The following is a description of a gene set: Temporal analysis of B cell activation in vitro using CD40L and IL-2/4/5 cytokines in wild type Irf4+/+ B cells or in mutant Irf4-/- B cells harboring a tet-inducible allele of Irf4. IRF4 expression was restored, or not, in the Irf4-/- background by culturing in the presence of low or high concentrations of doxycycline. The results provide insight in the role of IRF4 expression levels in coordinating different programs of B cell differentiation. Genes up-regulated in CD40L and IL-2 IL-4 IL-5 stimulated at day 1 B cell IRF4intermediate versus CD40L and IL-2 IL-4 IL-5 stimulated at day 1 B cell wildtype. from publication Ochiai K, Maienschein-Cline M, Simonetti G, Chen J, Rosenthal R, Brink R, Chong AS, Klein U, Dinner AR, Singh H, Sciammas R (PMID 23684984) Human Gene Set: GSE46606_IRF4MID_VS_WT_CD40L_IL2_IL5_DAY1_STIMULATED_BCELL_UP studied in species Homo sapiens, and this is the list of marker genes: NKAPL, TENT5C, ZNF250, PLXNC1, GINS1, HAGH, METTL9, CENPK, SGK1, POLR1D, VMAC, FAM78A, EPS8, TTC14, KMT2C, DTYMK, IFT70B, TSPYL4, ABCG1, APPL2, GTF2I, MKNK2, SEC22C, LAGE3, VAMP1, TXNIP, RAB11FIP5, IRAG2, GIGYF1, THBD, ZC3H12D, DIRAS2, KLF17, C2, KBTBD3, PWWP2B, SELENOH, RP9, MRM2, PDXK, PTPA, LSR, TCTN3, CDK20, COMT, ZNF124, SLC37A2, IFT140, STRBP, NHLRC2, TMEM18, ERCC6, E2F8, SKI, DENND4C, PCYOX1, NATD1, DDX31, SLC25A39, FBLIM1, NBEAL2, ZKSCAN1, PIP4K2B, PLEKHG3, MRTFA, MBP, CLK1, EIF4E3, PORCN, PNKP, MTCP1, MTUS1, TGFBR1, CRTC1, BORA, RNF166, MYCBP2, EYA4, FAM149B1, VSIR, CCDC77, TMEM14A, RASSF3, CNR2 (cannabinoid receptor 2), PLEKHM2, PYCARD, PEMT, KXD1, ARRDC1 (arrestin domain containing 1), MFSD6, KANK3, SBK1, SETD4, ELP2, NEMP1, ATF7IP, MAST3, CFAP119, NUDT6, PIAS3, ADAM15, CBX8, ZBTB45, RPA1, FOXO3, MAPKAPK3, NFKBIL1, IFFO1, SLC2A4RG, FBXO21, SUSD3, SNX32, WDR38, PDCD4, NEIL1, TMEM86A, KAT2A, MNT, LPAR6, SLC25A27, GBA2, CTDSPL, MINDY2 (MINDY lysine 48 deubiquitinase 2), TOX3, TCF12, HDAC5, NUDT16L1, TMEM19, MSH2, ATP5F1C, NUP43, KIF20B, PANK1, CBX3, OTULINL, SMYD4, GEN1, CDT1, IRF8, MRPS26, RPL3, POLR3G, B3GNT8, TTLL3, OSBPL7, RGS2, ARHGEF4, TEDC2, FNIP2, RASSF2, DGKZ, YDJC, MIA3, MISP, KIAA0930, KLF13, SDHB, PRXL2C, NCKIPSD, ATMIN, NHERF1, RAB19, ZFAND4, RCBTB2, PHF3, SZT2 (SZT2 subunit of KICSTOR complex), LRRC27 (NCBI Gene Id 92295), MBLAC2, VSTM2B, POLG2, BAZ1B, KIAA0586, WDR90, LAMP2, FAM168A, ZFP36L2, P2RY6, HARBI1, CCDC93, C16orf74, ABCD2, ANKRD13D, GPR183, NEURL1B, LYL1, MAP3K1, ARHGAP39, MAP3K9, ATP1B4, BORCS5, DDI2, MANSC1, FADS1, INSYN2A, RPS10, PTPN22, DROSHA, SNW1, TSC22D3